Given this list of marker genes ABTB3, NDP, TUBA1A, ATXN3, NLGN2, ABL2, MINAR2, ITGA3, APOE, VPS13A, GIP, BRINP1, ABAT, HTR1A, AGTR2, DCAF11, PRKCE, KMT2A, LRRK2, GAD1, BRINP3, DLG4, TNR, COMT, NAGLU, CHL1, CRH, JPH3, MYG1, NOG, CRBN, GABRB3, CRHR1, EIF4A3, PENK, GRN, DPP4, ATP1A2, SLC4A10, LRRTM1, here is a description of the gene set: studied in species Homo sapiens The specific behavior of an organism in response to a novel environment or stimulus. Human Gene Set: GOBP_EXPLORATION_BEHAVIOR